Given this list of marker genes RUVBL1, SEPHS2, RRP15 (ribosomal RNA processing 15 homolog), GPR183, MTG1, RPL13, COX10, WDR74, CAMSAP2, RPL5, UQCC3, VRK1, JAKMIP1, SUCLG1, RPL19, RNASEH2C (NCBI Gene Id 84153), BDH1, TDRP, MYL11, OTULINL, RPL29, ASF1A, SATB1 (SATB homeobox 1), MTAP, CHORDC1, ACADM, VPS4A, UTP25, YAE1, RPL36A, NRM, ADAMTS17, FGF13, KLHL6, CLNS1A (NCBI Gene Id 1207), CHID1, IL2RA (NCBI Gene Id 3559), HSD17B11, LEF1, SCARNA17, NME1, MTHFD1, ACYP1, BOLA2, AUP1, SSH2, PRMT7, RPS6KA3, CRTAM, CLYBL, SLCO3A1, DDX56, PSMG1, CYB5R4, ERP29 (NCBI Gene Id 10961), CMAHP (cytidine monophospho-N-acetylneuraminic acid hydroxylase, pseudogene), CD2BP2, IL7R, DNAJC15, THUMPD3, JAML, MRPS28, PFDN2, BAX, NT5E, PFDN5, NAA25, C18orf32, PARP8, NSMCE1, ANO10, CPM, IL15, DDX21, FCGR2B, WDR83OS, ALDOA, EI24, MTLN, POLI, KBTBD11, KLRG1, CHCHD5, DPH5, RETREG1, CMSS1, ZMAT2, EIF3G, SPATA6, PCBP1, RPL36, MRPL14, CSTF1, TUFM, DNAAF10, ZMAT5, UBR7, TESPA1, ACAA2, FOXP1, CTSW, EVL, HSPD1, SLC11A2, CD28, HDDC2, ATG5, BLTP3B, CCT6A, FAM162A, AXIN2, PTPN6, CDC34 (NCBI Gene Id 997), RPL13A, NOP10, RBM17, IRF2BP2, CRLF3, SMAP2, HAX1, MRPS18A, SGF29, MRPS18B, VPS26A, EEF1B2, NBN, GTF2H5, BCCIP, FBL, DMRTA1, WASHC3, FAM50A, EIF3H, FKBP4, QPCT, PIK3IP1, CD2AP, EEF1E1, SPG7, DKKL1, PRRG4, IDH2, EYA2, HLA-B, EMB, PRSS12, HS3ST3B1, HSD11B1, PRXL2A, MRPL23, ELP2, GZMM, PRDX3, RPL14, SNX1, KLK8, TCF7, IHH, RPLP1, TRAT1, ERAP1, WWP1, EEF1D, CDC26, PDLIM1, EPAS1, ANXA1, PSMD10, MRPL21, TTC27, RCN3, PRXL2C, HOPX, UTP14A, WDR75, LAMP1, RAB23 (RAB23, member RAS oncogene family), CBX7, here is a description of the gene set: species: Homo sapiens The development, homeostasis and function of B lymphocytes involve multiple rounds of B cell receptor (BCR)-controlled proliferation and prolonged maintenance. We analyzed the role of transcription factor Zfx, a recently identified regulator of stem cell maintenance, in B cell development and homeostasis. Conditional Zfx deletion in the bone marrow blocked B cell development at the pre-BCR selection checkpoint. Zfx deficiency in peripheral B cells caused impaired generation of the B-1 cell lineage, accelerated B cell turnover, depletion of mature recirculating cells, and delayed T-dependent antibody responses. Zfx-deficient B cells showed normal proximal BCR signaling, but impaired BCR-induced proliferation and survival. This was accompanied by aberrantly enhanced and prolonged integrated stress response, and delayed induction of Cyclin D2 and Bcl-xL proteins. Thus, Zfx restrains the stress response and couples antigen receptor signaling to B cell expansion and maintenance during development and peripheral homeostasis. Genes down-regulated in B lymphocytes: control versus stimulated by anti-IgM for 12h. from publication Arenzana TL, Smith-Raska MR, Reizis B (PMID 19329779) Human Gene Set: GSE13547_CTRL_VS_ANTI_IGM_STIM_BCELL_12H_DN